Given this list of marker genes Crip1, Atp5f1c, Cox4i1, Npc2, Cox7a2l, Idh1, Atp5mc2, Rgs10, Vamp5, Bri3, here is a description of the gene set: species: Mus musculus Cytokines mediate cell-cell communication in the immune system and represent important therapeutic targets. A myriad of studies have highlighted their central role in immune function, yet we lack a global view of the cellular responses of each immune cell type to each cytokine. To address this gap, the authors created the Immune Dictionary, a compendium of single-cell transcriptomic profiles of more than 17 immune cell types in response to each of 86 cytokines (>1,400 cytokine-cell type combinations) in mouse lymph nodes in vivo. A cytokine-centric view of the dictionary revealed that most cytokines induce highly cell-type-specific responses. For example, the inflammatory cytokine interleukin-1β induces distinct gene programmes in almost every cell type. A cell-type-centric view of the dictionary identified more than 66 cytokine-driven cellular polarization states across immune cell types, including previously uncharacterized states such as an interleukin-18-induced polyfunctional natural killer cell state. Mouse Gene Set: CUI_MACROPHAGE_IL36A_RESPONSE_DN Genes negatively differentially expressed in cell type: Macrophage upon treatment with cytokine: IL-36α in mouse lymph nodes in vivo. from publication Cui A, Huang T, Li S, Ma A, Pérez JL, Sander C, Keskin DB, Wu CJ, Fraenkel E, Hacohen N (PMID 38057668)